The following is a description of a gene set: An abnormally reduced amount of creatinine in the blood. Human Gene Set: HP_DECREASED_SERUM_CREATININE studied in species Homo sapiens Decreased serum creatinine, and this is the list of marker genes: NFE2L2, GALNT2 (polypeptide N-acetylgalactosaminyltransferase 2), NT5E, GAMT, AVPR2 (NCBI Gene Id 554)